The following is a description of a gene set: part of: Phase I - Functionalization of compounds This event has been computationally inferred from an event that has been demonstrated in another species.<p>The inference is based on the homology mapping from PANTHER. Briefly, reactions for which all involved PhysicalEntities (in input, output and catalyst) have a mapped orthologue/paralogue (for complexes at least 75% of components must have a mapping) are inferred to the other species. species: Mus musculus Reactome Pathway: COX reactions electronically inferred by orthology from the curated human pathway, and this is the list of marker genes: Ptgs1